The following is a description of a gene set: species: Mus musculus Binding to a cell adhesion molecule. Mouse Gene Set: GOMF_CELL_ADHESION_MOLECULE_BINDING, and this is the list of marker genes: Gsk3b, Cx3cl1, Myot, Nrg1, Sirpa, Itgav, Vtn, Akap5, Icam4, Tbc1d2, Pxn, Cdh18, Adam25, Tnc, Cd151, Adam26a, Ilk, Ctnna2, Emilin1, Slamf1, Ntng1, Itgb1bp1, Ppp1ca, Icam2, Cxadr, Adam18, Cd200r1, Col3a1, Itgb1bp2, Adam24, Cd46, Itga6, Ctnnd2, Kirrel3, Tenm3, Ptn, Cd40lg, Cdh4, Comp, Numb, Ccn3, Tspan8, Ctnna1, Fgg, Cadm1, Ank3, Cdh7, Cib2, Nf2 (neurofibromin 2), Ccn6, Thbs4 (thrombospondin 4), Cd200, Gpnmb, Calr, Ptpn6, Grin2b, Col16a1, Itgbl1, Mypn, Nectin2, Tjp3 (tight junction protein 3), Dmd, Cntn6, Itga2b, Mip, Pdia4, Ptpro, Cdh3, Arvcf, Bcam, Fermt1, P4hb, Slc14a2, Ctnnal1, Cdh15, Cdh9, Mmp24 (NCBI Gene Id 99226), Nrcam, Ccn1, Lama5, Itgb1, Tnn, Ctnnd1, Jam3, Lrp12, Ccn4, Ptpn11, Kdr, Icam5, S1pr3, Pkp2, Ptprj, Jup, Nectin3, Tln1, Ptprm, Cpe, Cdh19, Fbln5, Isg15, Itgb2l, Myh9, Thy1, Dscam, Nlgn1, Cdh23, Itga7, Clstn3, Fgf2, Slc6a4, Prom1, Nphs1, Timp2, Actn1, Nlgn2 (neuroligin 2), Adam15, Npnt, Fgf1, Cd81, Tenm1, Fgb, Lyn, Tspan4, F11r (NCBI Gene Id 226655), Ctnna3, Cdh2, Tln2, Cd9, Adam8, Rpsa, Sell, Nexn, Itgb8 (integrin beta 8), Igf1, Fermt3, Cd226, Il1b, Nfasc, Cdh6, Adam17, Itga3, Nos3, Pirb, Adgrl1, Tjp1, Ptpn2, Vsig10l2, Cdh12, Nos2 (nitric oxide synthase 2, inducible), Cdh5, Afdn, Jam2, Shtn1, Rdx, Ptprb, Lamb2, Fbn1, Vwf, Cd200l1, Cd177, Lgals8, Itga10, Cd1d1, Cdhr2, Anxa7, Esm1, Itga1, Jaml, Cdhr5, Itgb3, Obscn, Itga11, Tenm2, Vcam1, Itga9, Itga8, Gm1123, Fn1, Utrn, Cdh10, L1cam, Cdhr18, Dscaml1, Pkp1, Cdh8, Casr, Psen1, Nlgn3, Msn, Pkp4, Dst, Cdh20, Cd1d2, Cdh1, Fermt2, Itgam, Cntn1, Fxyd5, Itgb4, Ndrg1, Bmpr2, Ccn5, Ptprt, Tnr, Ninj1, Epcam (NCBI Gene Id 17075), Cd200l2, Tgfbi, Nectin1, Itgb2, Bsg, Itgax, Pkp3, Dchs1, Nptn, Src, Grin2a, Dsg2, Icam1, Spp1, Postn, Cd2ap, Prkca, Plxnb3, Nrxn2, P2rx4, Cldn7, Esam, Lamb1, Sdcbp, Gldn, Ccn2, Cdk5r1, Ppia, Tmigd1, Fga, Glycam1, Selp, Cdh22, Caml, Egfr, Emb, Cnga3, Itga4, Mmp14, Nisch, Itga5, Itgad, Igsf9, Hmgb1, Izumo1, Cxcl12, Prtg, Cdh17, Svep1, Itgal, Ctnnb1, Kirrel1, Tenm4, Cntn2, Ager, Itgb6, Frmd5, Cdh11, Ptprh, Cdh24, Itgae, Tcam1 (NCBI Gene Id 75870), Gfra1, Cntn5, Trpc4, Itgb7, Lrrc4c, Gfap, Emp2, Cd47, Thbs1, Acvr1, Fbln1, Mfge8 (milk fat globule EGF and factor V/VIII domain containing), Cdh13, Igf2, Ptk2, Ezr, Ptprf, Neo1, Madcam1, Lilrb4a, Fgfr1, App, Dab2, Itgb5, Fap, Mcam, Olfm4, Lcp1, Col4a3, Tjp2, Pvr, Ibsp, Adam9, Itga2, Nrxn1, Ptprd, Angptl3, Ptprz1, Sema7a, S1pr2, Cdh26, Plpp3 (phospholipid phosphatase 3), Rtn4, Syk, Kirrel2